The following is a description of a gene set: Mouse Gene Set: CUI_CDC2_CD27L_RESPONSE_DN from publication Cui A, Huang T, Li S, Ma A, Pérez JL, Sander C, Keskin DB, Wu CJ, Fraenkel E, Hacohen N (PMID 38057668) Cytokines mediate cell-cell communication in the immune system and represent important therapeutic targets. A myriad of studies have highlighted their central role in immune function, yet we lack a global view of the cellular responses of each immune cell type to each cytokine. To address this gap, the authors created the Immune Dictionary, a compendium of single-cell transcriptomic profiles of more than 17 immune cell types in response to each of 86 cytokines (>1,400 cytokine-cell type combinations) in mouse lymph nodes in vivo. A cytokine-centric view of the dictionary revealed that most cytokines induce highly cell-type-specific responses. For example, the inflammatory cytokine interleukin-1β induces distinct gene programmes in almost every cell type. A cell-type-centric view of the dictionary identified more than 66 cytokine-driven cellular polarization states across immune cell types, including previously uncharacterized states such as an interleukin-18-induced polyfunctional natural killer cell state. Genes negatively differentially expressed in cell type: cDC2 (conventional dendritic cell type 2) upon treatment with cytokine: CD27L in mouse lymph nodes in vivo. species: Mus musculus, and this is the list of marker genes: Fos, Zfp36, Btg2, Dusp1, Fosb, Atf3, Hspa1a